The following is a description of a gene set: Human Gene Set: GAVISH_3CA_METAPROGRAM_EPITHELIAL_EPI4 from publication Gavish A, Tyler M, Greenwald AC, Hoefflin R, Simkin D, Tschernichovsky R, Galili Darnell N, Somech E, Barbolin C, Antman T, Kovarsky D, Barrett T, Gonzalez Castro LN, Halder D, Chanoch-Myers R, Laffy J, Mints M, Wider A, Tal R, Spitzer A, Hara T, Raitses-Gurevich M, Stossel C, Golan T, Tirosh A, Suvà ML, Puram SV, Tirosh I (PMID 37258682) In this study, an extensive analysis was conducted to define meta-programs (MPs) capturing intra-tumor heterogeneity across a spectrum of tumor types. The approach utilized non-negative matrix factorization (NMF) to analyze each cell type separately within individual tumor samples. This involved the analysis of malignant cells, macrophages, fibroblasts, endothelial cells, epithelial cells, T-cells, and B-cells. NMF was executed with varying parameter values (K=4, 5, 6, 7, 8, 9), thereby generating 39 programs for each cell type per sample. Each NMF program was summarized by the top genes based on NMF coefficients.\nRobust MPs were then delineated for each cell type using a set of stringent criteria, including recurrence within the same tumor, similarity to programs in other tumors, and non-redundancy within a tumor. Subsequently, these robust NMF programs were clustered (per cell type) based on Jaccard similarity, leading to the identification of MPs associated with each cell type.\nTo enhance the quality of the MPs, a refinement steps were undertaken, involving the removal of MPs suspected of reflecting low-quality data (with an overrepresentation of ribosomal proteins or mitochondrial-encoded genes), single-study inclusion, or similarity to miss-annotated cell types. Genes upregulated in subsets of cells of a given type within various tumors species: Homo sapiens, and this is the list of marker genes: BSG, MYDGF, TACSTD2, SYNGR2, TMEM59, ITGB1, LY6E, PAEP, SYPL1, PERP, APP, CD63, EPCAM, NAPSA, TMED9, WFDC2, CALR, TFPI, LMAN1, LGALS3BP, APLP2, NPC2, SFTPB, PDIA3, ITM2B, PSAP, HLA-A, BCAM, ICAM1 (intercellular adhesion molecule 1), CCL20, CEACAM6, TMED10, PPIB, CD74, TSPAN13, SPINT2, CST3, CD9, CANX, CTSH, HLA-B, P4HB, PDIA6, TMCO1, CD47, AREG, TMED2, LAPTM4A, AGR2 (anterior gradient 2, protein disulphide isomerase family member), HSP90B1